The following is a description of a gene set: Mouse Gene Set: GOBP_SULFUR_AMINO_ACID_METABOLIC_PROCESS The chemical reactions and pathways involving amino acids containing sulfur, comprising cysteine, homocysteine, methionine and selenocysteine. studied in species Mus musculus, and this is the list of marker genes: Mpst, Adi1, Mtr, Mthfd1, Cacna1a, Comt, Bhmt, Mthfd2l, Ggt1, Gnmt, Mri1, Mmut, Dpep1, Enoph1, Cdo1 (cysteine dioxygenase 1, cytosolic), Mtrr, Bhmt1b, Cps1, Bhmt2, Mat1a, Agxt, Csad, Apip, Cbs (cystathionine beta-synthase), Cth, Nox4, Mtap, Gclm, Slc7a11, Blmh, Mthfr, Gclc